Given this list of marker genes LMBRD1, ABCD4, MTRR, MMACHC, MTHFD1, PRDX1, MMADHC, MTR, here is a description of the gene set: studied in species Homo sapiens The concentration of methylcobalamin in the blood circulation is below the lower limit of normal. Methylcobalamin is a form of vitamin B12. Decreased circulating methylcobalamin concentration Human Gene Set: HP_DECREASED_CIRCULATING_METHYLCOBALAMIN_CONCENTRATION